The following is a description of a gene set: species: Homo sapiens Human Gene Set: GOBP_PRIMARY_AMINO_COMPOUND_BIOSYNTHETIC_PROCESS The chemical reactions and pathways resulting in the formation of primary amino compound., and this is the list of marker genes: ALDH2 (aldehyde dehydrogenase 2 family member), TPH2, AZIN2, TPH1, DDC, AGMAT